The following is a description of a gene set: EGF receptor (ErbB1) signaling pathway studied in species Homo sapiens Human Gene Set: PID_ERBB1_RECEPTOR_PROXIMAL_PATHWAY from publication Schaefer CF, Anthony K, Krupa S, Buchoff J, Day M, Hannay T, Buetow KH (PMID 18832364), and this is the list of marker genes: WASL, MAPK3, SHC1 (NCBI Gene Id 6464), PIK3CD, KRAS, SOS1, PAK1, GAB1, PIK3R3, GNAI1, GSN, PTPN1, PIK3R2, PTPN6, PIP5K1C, NCK2, PIK3CB, GRB2, TLN1, GNAI3 (G protein subunit alpha i3), PIK3R1, MAPK1, PLCG1, STAT1, PTK2, NCK1, RASA1 (RAS p21 protein activator 1), EGF, SRC, STAT3, HRAS, PIK3CA, PTPN11, EGFR (NCBI Gene Id 1956), NRAS